Given this list of marker genes Sesn2, Eif4g1, D1Pas1, Nck2, Dnajc3, Tmed2, Ddx3x, Eif2ak3, Eif2ak4, Eif2s1, Nck1, Map3k20, here is a description of the gene set: studied in species Mus musculus Mouse Gene Set: GOBP_REGULATION_OF_TRANSLATION_IN_RESPONSE_TO_ENDOPLASMIC_RETICULUM_STRESS Modulation of the frequency, rate or extent of translation as a result of endoplasmic reticulum stress.